The following is a description of a gene set: MET interacts with TNS proteins Mouse Gene Set: REACTOME_MET_INTERACTS_WITH_TNS_PROTEINS studied in species Mus musculus, and this is the list of marker genes: Tns4, Met, Itgb1, Tns3, Hgf (hepatocyte growth factor)